The following is a description of a gene set: Mouse Gene Set: REACTOME_BUTYRATE_RESPONSE_FACTOR_1_BRF1_BINDS_AND_DESTABILIZES_MRNA species: Mus musculus Butyrate Response Factor 1 (BRF1) binds and destabilizes mRNA, and this is the list of marker genes: Exosc1, Zfp36l1 (zinc finger protein 36, C3H type-like 1), Dcp2, Exosc5, Exosc3, Exosc8, Exosc6 (exosome component 6), Exosc7, Dis3, Mapkapk2, Xrn1, Exosc2, Exosc4, Akt1 (thymoma viral proto-oncogene 1), Dcp1a, Exosc9, Ywhab (tyrosine 3-monooxygenase/tryptophan 5-monooxygenase activation protein, beta polypeptide)